The following is a description of a gene set: species: Homo sapiens Defensins Human Gene Set: REACTOME_DEFENSINS, and this is the list of marker genes: DEFB113, DEFB132, DEFB114, DEFB134, DEFA1, TLR1, DEFB1, DEFB119, DEFB135, DEFB115, DEFB107A, TLR2 (toll like receptor 2), DEFB118, DEFB125, DEFA5, DEFB133, CD4, PRSS2, DEFA3, DEFB108B, DEFB103A, DEFB123, DEFB110, DEFB106B, DEFB106A, DEFB116, DEFB126, DEFB105A, CCR6, DEFB136, DEFB4B, ART1, DEFB131A, CCR2, DEFB104A, DEFB127, DEFB129, DEFB104B, DEFA4, DEFB130B (defensin beta 130B), DEFB109B, PRSS3, DEFB105B, DEFB121, DEFB124, DEFB107B, DEFA6, DEFB103B, DEFB112, DEFB128, DEFB130A, DEFA1B, DEFB4A